Given this list of marker genes GNA15, ZNF136, CCL18, MEOX1, PTPN7, PRKCB, IL1RAP, ATF3 (NCBI Gene Id 467), MSX1, DNM2, TRAF6, ZMYM3 (NCBI Gene Id 9203), COIL, DLEC1, TOB2, DLK1, RUNX1, TBR1, LTK, PTPRS, CDKN1A, here is a description of the gene set: studied in species Homo sapiens Human Gene Set: HOFMANN_MYELODYSPLASTIC_SYNDROM_LOW_RISK_UP from publication Hofmann WK, de Vos S, Komor M, Hoelzer D, Wachsman W, Koeffler HP (PMID 12411319) Gene patterns of expression in purified CD34(+) bone marrow cells from 7 patients with low-risk myelodysplastic syndrome (MDS) and 4 patients with high-risk MDS were compared with expression data from CD34(+) bone marrow cells from 4 healthy control subjects. CD34(+) cells were isolated by magnetic cell separation, and high-density oligonucleotide microarray analysis was performed. For confirmation, the expression of selected genes was analyzed by real-time polymerase chain reaction. Class membership prediction analysis selected genes. Using the expression profile of these genes, we were able to discriminate patients with low-risk from patients with high-risk MDS and both patient groups from the control group by hierarchical clustering (Spearman confidence). The power of these genes was verified by applying the algorithm to an unknown test set containing expression data from 8 additional patients with MDS (3 at low risk, 5 at high risk). Patients at low risk could be distinguished from those at high risk by clustering analysis. In low-risk MDS, we found that the retinoic-acid-induced gene (RAI3), the radiation-inducible, immediate-early response gene (IEX1), and the stress-induced phosphoprotein 1 (STIP1) were down-regulated. These data suggest that CD34(+) cells from patients with low-risk MDS lack defensive proteins, resulting in their susceptibility to cell damage. In summary, we propose that gene expression profiling may have clinical relevance for risk evaluation in MDS at the time of initial diagnosis. Furthermore, this study provides evidence that in MDS, hematopoietic stem cells accumulate defects that prevent normal hematopoiesis. Genes up-regulated in bone marrow hematopoietic stem cells (HSC, CD34+) from patients with low risk of myelodysplastic syndrome (MDS) compared with healthy controls.